Given this list of marker genes CDKN1C, E2F4, RB1 (RB transcriptional corepressor 1), UBB, CCND3, PPP2R2A, PPP2R1A, PPP2CA, CDK7, SKP2, CCNH, UBA52, CCNE2, RBL2, CDK6, E2F5, E2F2, CDKN2C, RBL1, CDKN2A, UBC, CCND1, CDK4, PTK6, CKS1B, LYN, TFDP1, MNAT1, PPP2CB, CDKN1A, E2F1, CCND2, CDKN2B, ABL1, SRC, CUL1, TFDP2, CDK2, CDKN2D, PPP2R3B, CDKN1B, SKP1, JAK2 (NCBI Gene Id 3717), E2F3, CCNE1, PPP2R1B (protein phosphatase 2 scaffold subunit Abeta), RPS27A, here is a description of the gene set: Reactome Pathway: Cyclin D associated events in G1 Three D-type cyclins are essential for progression from G1 to S-phase. These D cyclins bind to and activate both CDK4 and CDK6. The formation of all possible complexes between the D-type cyclins and CDK4/6 is promoted by the proteins, p21(CIP1/WAF1) and p27(KIP1). The cyclin-dependent kinases are then activated due to phosphorylation by CAK. The cyclin dependent kinases phosphorylate the RB1 protein and RB1-related proteins p107 (RBL1) and p130 (RBL2). Phosphorylation of RB1 leads to release of activating E2F transcription factors (E2F1, E2F2 and E2F3). After repressor E2Fs (E2F4 and E2F5) dissociate from phosphorylated RBL1 and RBL2, activating E2Fs bind to E2F promoter sites, stimulating transcription of cell cycle genes, which then results in proper G1/S transition. The binding and sequestration of p27Kip may also contribute to the activation of CDK2 cyclin E/CDK2 cyclin A complexes at the G1/S transition. part of: G1 Phase studied in species Homo sapiens